Given this list of marker genes NSMCE4A, UBB, NSMCE3, RNF168, NSMCE1 (NCBI Gene Id 197370), SMC5 (NCBI Gene Id 23137), RAD18, SMC6, NSMCE2, SLF1, SLF2, here is a description of the gene set: Pathway Definition from KEGG: RNF168 -> RAD18+UBB == SLF1+SLF2 == SMC5-SMC6 Loading of the SMC5-SMC6 complex. Pathway ID: N01636. Pathway type: Reference. Pathway class: nt06506 Double-strand break repair. Human Gene Set: KEGG_MEDICUS_REFERENCE_LOADING_OF_THE_SMC5_SMC6_COMPLEX species: Homo sapiens